Given this list of marker genes Enoph1, Glud1, Mpst, Asl (argininosuccinate lyase), Gcdh, Psma3, Aspg, Pipox, Psmb1, Il4i1, Bhmt2, Pycr3, Gadl1, Asns, Aldh18a1, Ahcy, Cbs, Got2, Sat1, Hpd, Dmgdh, Kynu, Fmo1, Pycr1, Gnmt, Gpt (glutamic pyruvic transaminase, soluble), Psmc2 (proteasome (prosome, macropain) 26S subunit, ATPase 2), Ckmt1 (NCBI Gene Id 12716), Aldh7a1, Ethe1, Bcat1, Psmd8, Hykk, Cth, Ass1, Mtap, Gcsh, Psmc3, Got1, Psmc6, Amd1, Pcbd1, Bckdk, Gatm, Bcat2, Oca2, Tph2, Oaz1, Grhpr, Dlst, Smox, Asmt (acetylserotonin O-methyltransferase), Nat8l, Oaz3, Aass, Psma2, Carnmt1, Slc6a7, Psat1, Psmd14 (proteasome (prosome, macropain) 26S subunit, non-ATPase, 14), Hoga1, Mccc2, Uroc1, Carns1, Bhmt, Psmb5, Rida, Ido1, Aanat, Bckdhb, Kyat1, Hgd, Mtr, Psph, Psmd1, Kmo, Aldh6a1, Tat, Psmb2, Gpt2, Psmc1, Scly, Psmb7, Txn2, Ppm1k, Pycr2, Fah (NCBI Gene Id 14085), Slc25a13, Arg2, Mtrr, Arg1, Cga, Psmc4, Phykpl, Prodh, Nqo1, Tstd1, Cps1, Srm, Ckmt2, Gamt, Duox1, Dao (NCBI Gene Id 13142), Oaz2, Slc25a12, Dbh, Psmd2, Psmd13, Dct, Aldh4a1, Gls, Slc44a1, Asrgl1, Dhtkd1, Sephs2 (selenophosphate synthetase 2), Slc25a21 (NCBI Gene Id 217593), Tyr, Mrps36, Haao, Tyrp1, Pnmt, Ddc, Gls2, Slc25a15, Slc3a2, Agxt, Glul, Psma5, Psmd6, Bhmt1b, Ftcd, Psmd11, Psma1, Txnrd1, Tdo2, Serinc5, Serinc1, Acat1, Slc6a11, Ahcyl (adenosylhomocysteinase like), Psmd7, Adi1, Tph1 (NCBI Gene Id 21990), Aspa, Psma4, Aldh9a1, Otc, Ogdh, Nags, Oat, Phgdh, Bbox1, Ado, Slc25a2, Crym, Auh, Slc7a5, Psmb3, Ckm, Psmd3, Hsd17b10, Acad8, Th (tyrosine hydroxylase), Hibadh (3-hydroxyisobutyrate dehydrogenase), Prodh2, Srr, Hao1, Tst, Chdh, Paox, Slc25a10, Dbt (dihydrolipoamide branched chain transacylase E2), Dio3, Qdpr, Sds, Odc1, Psma6, Sardh, Serinc4, Mri1, Ido2, Adrm1, Agmat, Ivd, Hibch, Tshb, Azin2, Sms, Dio1, Psmc5, Echs1, Agxt2, Psma7, Mccc1, Gstz1, Aadat, Psmb4, Cdo1, Acadsb, Folh1, Mat1a, Iyd, Psmd12, Hal, Naalad2, Sqor, Slc6a8, Serinc2 (serine incorporator 2), Amdhd1, Bckdha, Slc5a5, Suox, Ckb, Ddo, Amt, Azin1, Serinc3, Gldc, Dld, Shmt1, Duox2, Sdsl, Nmral1, Tpo, Pah, Psmb6, Rimkla, Slc36a4, Slc45a2, Rimklb, Slc6a12, Hdc, here is a description of the gene set: studied in species Mus musculus Mouse Gene Set: REACTOME_METABOLISM_OF_AMINO_ACIDS_AND_DERIVATIVES Metabolism of amino acids and derivatives